The following is a description of a gene set: from publication Haribhai D, Lin W, Edwards B, Ziegelbauer J, Salzman NH, Carlson MR, Li SH, Simpson PM, Chatila TA, Williams CB (PMID 19265124) studied in species Homo sapiens The gene expression profile of peripheral Foxp3+ natural regulatory T cells isolated from Foxp3/EGFP bicistronic mice was compared to that of in vitro-induced regulatory T cells and to CD4+ conventional (Foxp3-) T cells. The role of the regulatory T cell transcription factor Foxp3 in shaping the transcriptosomes of natural and induced regulatory T cells was analyzed using mice expressing a mutant FOXP3-EGFP fusion protein (Foxp3deltaEGFP). We used gene expression microarrays to examine the transcriptional programs of natural and induced regulatory T cells and the function of Foxp3 in organizing the transcriptosomes of the respective cell type Genes up-regulated in natural T reg: wildtype versus non-functional FOXP3. Human Gene Set: GSE14415_NATURAL_TREG_VS_FOXP3_KO_NATURAL_TREG_UP, and this is the list of marker genes: MAP3K12, ITPR2, TOP1, ABCG4, ULK2, TRPM4, SMPD2, TRAF5, VPREB1, TRIM5, TMCO2, FAM161B, SYT17 (NCBI Gene Id 51760), LACTB, KAT6B, GGA3, BST2, CAVIN4, LCORL, HOMER1, CAPN9, CHORDC1, CFLAR, MAML2, CD300LG, COX8C, ATP6V1G2, LGALS3, SRXN1, SRD5A2, RSAD2, KIZ, KLK13, NRARP, CD226, STAP1, SYCP1 (synaptonemal complex protein 1), MPO, DST, SAMD9L, CCR9, SERPINI1, CCL2, C1QC, RIGI, DMXL1, BDP1, GLT8D1, NETO2, BMAL1, ZBTB48, CD5L, ZDHHC15, ING1, PBK, IGDCC4, ADRB2, PDE6D, DPH6, ACOT11, UHRF2, DUSP14, PYHIN1, KIF27, CCL5, TSGA10, RABEP1, MS4A3, IFIT1, CD164L2, CEBPZ, APOE, GGCT, CD7, NCOA7, FAM120B, CD48, B3GALT1, CXCR6, DNAJB3, SMOC1, GEM (NCBI Gene Id 2669), GRHL3, MLF1, RSPRY1, PHF20L1, HOPX, QRICH2, DNAJB9, KLK8, IFIT3 (NCBI Gene Id 8376), CHD3 (NCBI Gene Id 1107), CEP170 (centrosomal protein 170), MYH11, CDC42EP3, KRTAP6-3, IFI44, DDX60, SP100, GVINP1, CD38, ARHGAP39, FRY, PLXDC1 (NCBI Gene Id 57125), DZIP3, HSPA2, PPP1R12A, CD24, UROS, TTC9C, RAB42, VAMP5, MDFIC, RPL24, CD55, AP1S2, KLRC1, RAPSN (receptor associated protein of the synapse), CD86, MYH1, SYT10, QRFPR, SYNE1, GALM, NQO2, MPPE1, L1CAM (L1 cell adhesion molecule), NHLH1, ZEB2, F13A1, PCM1, SCGB1C1, KLRC2, TBC1D9B, TMF1, MIR500A, RAB21, CRELD2, RAMP1, RHOB, JOSD2, GBP5, NEIL1, USH1C, SLC45A3, METTL8, NES, CEP112, FCGR2B, SRGAP3, CD3G, TDRD6